The following is a description of a gene set: studied in species Homo sapiens from publication Bandres E, Andion E, Escalada A, Honorato B, Catalan V, Cubedo E, Cordeu L, Garcia F, Zarate R, Zabalegui N, Garcia-Foncillas J (PMID 15980968) Genes down-regulated in A172 cells (glioma, does not express MGMT) by carmustine at 24 h. Chemotherapy with the alkylating agent BCNU (1,3-bis (2-chloroethyl)-1-nitrosourea) is the most commonly used chemotherapeutic agent for gliomas. However, the usefulness of this agent is limited because tumor cell resistance to BCNU is frequently found in clinical brain tumor therapy. The O6-methylguanine-DNA methyltransferase protein (MGMT) reverses alkylation at the O6 position of guanine and we have reported the role of MGMT in the response of brain tumors to alkylating agents. However, the different mechanisms underlying the patterns related to MGMT remain unclear. To better understand the molecular mechanism by which BCNU exerts its effect in glioma cell lines according MGMT expression, we used microarray technology to interrogate 3800 known genes and determine the gene expression profiles altered by BCNU treatment. Our results showed that treatment with BCNU alters the expression of a diverse group of genes in a time-dependent manner. A subset of gene changes was found common in both glioma cell lines and other subset is specific of each cell line. After 24 h of BCNU treatment, up-regulation of transcription factors involved in the nucleation of both RNA polymerase II and III transcription initiation complexes was reported. Interestingly, BCNU promoted the expression of actin-dependent regulators of chromatin. Similar effects were found with higher BCNU doses in MGMT+ cell line showing a similar mechanism that in MGMT-deficient cell with standard doses. Our data suggest that human glioma cell lines treated with BCNU, independently of MGMT expression, show changes in the expression of cell cycle and survival-related genes interfering the transcription mechanisms and the chromatin regulation. Human Gene Set: BANDRES_RESPONSE_TO_CARMUSTIN_WITHOUT_MGMT_24HR_DN, and this is the list of marker genes: GOLGA2, INPPL1 (inositol polyphosphate phosphatase like 1), HADH, GTF2F1, FNTA, RCN1, ACTN1 (NCBI Gene Id 87), SLCO1A2, TLE3